The following is a description of a gene set: Human Gene Set: KEGG_MEDICUS_VARIANT_AMPLIFIED_FGFR_TO_RAS_ERK_SIGNALING_PATHWAY Amplified FGFR to RAS-ERK signaling pathway. Pathway ID: N00020. Pathway type: Variant. Pathway class: nt06261 Gastric cancer. species: Homo sapiens Pathway Definition from KEGG: FGFR* -> GRB2 -> SOS -> RAS -> RAF -> MEK -> ERK, and this is the list of marker genes: KRAS, BRAF, SOS1 (NCBI Gene Id 7838), NRAS, FGFR1, MAPK1, MAP2K1, RAF1, FGFR2, MAPK3, SOS2, GRB2, ARAF, HRAS, MAP2K2